Given this list of marker genes HSP90AB1, POLR2I, RHOC, USP40, ZNF276, LYVE1, TRIM68, MVD, POU2AF2, THOP1, DCSTAMP, ARK2N, ABCC9 (ATP binding cassette subfamily C member 9), DAB2, SAA1, THSD1, GBP6, TLR8, SUFU, NOBOX, SOD1, CCDC171, RFX5, CAPS2, SOCS5, PAFAH1B1, UBE4A, SLC38A7, RFK, RAB39A, PLA2G5, PPEF2, CYB561A3, ADAMTS7, MMD, CYP2B6, CYP2F1, TBC1D13, TTC29, FOXD3, BTBD19, MAPK8IP2, AP1M2, YIPF4, ZNF516, TNFRSF8, NECTIN3, FAM20A, AKIRIN2, MBD5, LYPD3, PPP1R2P1, UFD1, TMEM212, SKA3, POLR3K, MADD, TOR1AIP2, C14orf93, MAK, BYSL, ART1, PRRG2, GPM6B, ZNF580, SCNN1G, NOVA1, PPP1R1B, ATP2B3, KRT28, BPIFA2, CYP4A22, NBEA, WDPCP, P2RX1, FRZB, EXO1, LRFN1, DNAJC3, AANAT (NCBI Gene Id 15), PORCN, ZG16 (zymogen granule protein 16), SLC38A3, CES3, LGALS3BP, PLEKHN1, TBX21, MORF4L2, MDC1, IRF4 (interferon regulatory factor 4), TSR2, PDXK, TNNI2, INCENP, FOXB1, SLC30A10, LTN1, UPK3A, TOM1, RASSF9, PDE6B (phosphodiesterase 6B), TOR1AIP1, SPACA4, BASP1, KCNK2, ZFTA, JMJD4, BHLHE22, CST8, EPB42, PAGR1, SRCIN1, PARP14, SV2B, SLC25A3, TMOD1, WNT5A, RAD52, ARSI, PANX1, SEMA3C, DQX1, CERS4, RTL3, C12orf71, TIMD4, LYG1, EEF1E1, SLC22A16, CARMIL1, STARD4, CMPK2, DBF4 (DBF4-CDC7 kinase regulatory subunit), YWHAG, COL19A1, FMO1, EXOC3L2, COL27A1, NUTF2, YIF1B, SETD5, ENOPH1, COMMD7, SIX1, NTRK1, CD47, GAS1, HS3ST2, TMEM87B, SH2D6 (NCBI Gene Id 284948), MRPS25, PPP1R3F, SYNE2, NIBAN3, SLC43A1, EXOSC6, AP2B1, AQP3, ASPRV1, PAFAH1B2, PRKAR2A, SETD6, SGO1, SH3RF3, ZNF131, WRAP53, TNP2, MSH4, NXPH4, GPR171, PRPF19, DLST, LOX, MRPS6, CD93, GLYAT, PRSS16, TMEM63B, PERP, TAOK3 (NCBI Gene Id 51347), TENM1, DIS3L, PLOD2, DEGS2, RBM15B, HIF1AN, HOXA4, CC2D1A, DNPEP, IGF1, PSCA, IL17RC, HYLS1, SF1, PAK3, ADGRF5, CAMK2A (NCBI Gene Id 815), MRGPRE, ACSBG2, SHC4 (SHC adaptor protein 4), here is a description of the gene set: studied in species Homo sapiens Human Gene Set: GSE2770_UNTREATED_VS_TGFB_AND_IL12_TREATED_ACT_CD4_TCELL_6H_DN Th1 and Th2 cells arise from a common precursor cell in response to triggering through the TCR and cytokine receptors for IL-12 or IL-4. This leads to activation of complex signaling pathways, which are not known in detail. Disturbances in the balance between type 1 and type 2 responses can lead to certain immune-mediated diseases. Thus, it is important to understand how Th1 and Th2 cells are generated. To clarify the mechanisms as to how IL-12 and IL-4 induce Th1 and Th2 differentiation and how TGF-beta can inhibit this process, we have used oligonucleotide arrays to examine the early polarization of Th1 and Th2 cells in the presence and absence of TGF-beta after 0, 2, 6 and 48 hours of polarization. from publication Lund R, Aittokallio T, Nevalainen O, Lahesmaa R (PMID 14607935) Genes down-regulated in CD4 T cells: untreated (0h) versus activated by anti-CD3 and anti-CD28 and then stimulated by TGFB1 and IL-12 (6h).